Given this list of marker genes XXYLT1, CACYBP, ZBTB39, POU4F3, NRIP1, TSPYL4, MRPL20-AS1, C1orf216, PDZK1IP1, DMP1, P4HTM, MIA, KLK7, ROS1, ZNF235, ABCC2, EML2, UQCRC2, TMIE, HBP1, ICAM2, MDH1B, MZT2B, SLC13A2, KATNAL2, NTRK3, ZIC1, ARRB1, CYP3A7, KDM5C, MRPS25, SLAMF9, MRPL10, PLXNB1, CPT2, ITPRIPL2, ITGA8, FIGN, KCTD21, C1QL3, PHPT1, TSSK2, RGN, CELF3, FHIP1A, MPPED2, KIF3A, FAM120B, FRMD4A (NCBI Gene Id 55691), POU5F2, SH3BP5, IL17RB, FKBP1B, REXO2, KMO, MACROD2, DYNLRB2, ZNF507, GLB1L2, CWF19L1, C11orf71, AKT3, HSPH1, PTPRS, TBC1D15, HMBOX1, CADPS2, SMO, ZNF219, ZNF319, CTH, SFTPB, PECR, LRRC3B, SLC20A2, VCF1, TJP2, COQ8A, VAMP5, KRTAP26-1, ZMYM5, INPPL1, KCNH1, LTC4S, NPHS2, OXTR, KLF4, PKM, PNPO, SYDE1, MYF5, CRYBG2, PTPN3, MYO16, PIGY, ADISSP, IFT27, NLE1, TAX1BP1, N4BP2, EPHX1, TMEM63C, DYNLT5, MBOAT4, UQCRFS1, TMEM65, DNAJC13, NCR1, ZNF563, SHISA2, VASH2, STYXL2, C1orf54, CDK8 (NCBI Gene Id 1024), GPR68, RSPH3, FBXO32, CFAP97, RGS8, SOAT2, ACOT13, PTGES2, TBC1D17, C1orf210, IL1R1, CLIP3, RHOB, ABCC3, RORC, GLRX2, DNAJB7, KLK10, ZNF189 (NCBI Gene Id 7743), CBLN4, GDA, SCHIP1, PCDHB10, USP22, GZMM, CLCNKA, ECSIT, IFI27, IRAK1BP1, TF, MSRA, TTC28, ZNF142, GLRA4, DGKG, ALAS1, ARHGEF40, PPP1R17, MAP7, STIM1, LRRTM4, KMT5B, ASB5, PNKD, PLCZ1, NT5E, ATP10B, VCL, DNAJC28, TNFRSF19, DDX51, LYL1, PSORS1C2 (NCBI Gene Id 29112), STX3, CYP4A11, SRSF6, SBSN, HPCAL1, REEP2, IFT140, RCVRN, ENDOD1, DDB1 (NCBI Gene Id 1642), HOXA11, TST, TMEM238, IL1R2, CAMSAP3, ARHGAP18, ZC3HAV1L, CLIP2, TRIM15 (tripartite motif containing 15), PCNX1, MECR, FCRL1, RPP25, GREB1L, CERS4, KLF9, TICAM1, EGFL6, XKRX, ZNF551, PTPRN2, here is a description of the gene set: studied in species Homo sapiens Human Gene Set: GSE36078_UNTREATED_VS_AD5_T425A_HEXON_INF_IL1R_KO_MOUSE_LUNG_DC_DN from publication Doronin K, Flatt JW, Di Paolo NC, Khare R, Kalyuzhniy O, Acchione M, Sumida JP, Ohto U, Shimizu T, Akashi-Takamura S, Miyake K, MacDonald JW, Bammler TK, Beyer RP, Farin FM, Stewart PL, Shayakhmetov DM (PMID 23019612) Discrimination between self vs. non-self and adequate response to infection and tissue damage are fundamental functions of the immune system. The rapid and global spread of known and emerging viruses is a testament that the timely detection of viral pathogens that reproduce within host cells, presents a formidable challenge to the immune system. To gain access to a proper reproductive niche, many pathogens travel via the host vasculature and therefore become exposed to humoral factors of the innate immune system. Although a cascade of coagulation factors plays a fundamental role in host defense for “living fossils” such as horseshoe crabs (Xiphosurida spp), the role of the coagulation system in activation of innate responses to pathogens in higher organisms remains unclear. When human type C adenovirus (HAdv) enters the circulation, 240 copies of coagulation factor X (FX) bind to the virus particle with picomolar affinity. Here, using molecular dynamics flexible fitting (MDFF) and high resolution cryo-electron microscopy (cryo-EM), we defined the interface between the HAdv5 hexon protein and FX at pseudo-atomic level. Based on this structural data, we introduced a single amino acid substitution, T424A, in the hexon that completely abrogated FX interaction with the virus. In vivo genome-wide transcriptional profiling revealed that FX-binding-ablated virus failed to activate a distinct network of the early response genes, whose expression depends on transcription factor NFKB1. Deconvolution of the signaling network responsible for early gene activation showed that the FX-HAdv complex triggers MyD88/TRIF/TRAF6 signaling upon activation of toll-like receptor 4 (TLR4) that serves as a principal sensor of FX-virus complex in vivo. Our study implicates host factor “decoration” of the virus as a mechanism to trigger innate immune sensor that respond to a misplacement of coagulation FX from the blood into intracellular macrophage compartments upon virus entry into the cell. Our results further the mounting evidence of evolutionary conservation between the coagulation system and innate immunity. Genes down-regulated in Lung dendritic cell from untreated IL-1R mice versus Lung dendritic cell from Ad5 T424A hexon inf IL-1R mice.